Given this list of marker genes MT-TV, MRM2, MT-ATP6 (mitochondrially encoded ATP synthase membrane subunit 6), OAT, ATP5F1A, CA5A, ADK, ALDH18A1, MT-ND6, NOS3, ASL, APP, ALDH5A1, MT-ND5, MT-TW, MT-TK, USP53, SLC25A15, SLC7A7, MT-ND2, CPS1, DMGDH, MT-ND3, MT-ND1, AASS, KYNU, UPB1, MPO, MT-ND4, PLAU, PCK1, OTC, ASS1, MT-TL1, SLC25A13, NAGS, here is a description of the gene set: Human Gene Set: HP_ABNORMAL_CIRCULATING_NON_PROTEINOGENIC_AMINO_ACID_CONCENTRATION Any deviation from the normal concentration in the blood circulation of an alpha-amino acid which is not a member of the group of 23 proteinogenic amino acids. Abnormal circulating non-proteinogenic amino acid concentration species: Homo sapiens